Given this list of marker genes USP14, RAB6B, ATF6B, BBS5, ADCY6, B9D1, SPRY2, GDI1, TARDBP (TAR DNA binding protein), HECTD1, OTX1, ZFYVE9, CTAGE1, POU2F1, PDE12, U2SURP, ELAVL1 (ELAV like RNA binding protein 1), TIPARP, CYB561D1, N4BP3, SKAP2, TUBAL3, PTBP2, KMT2B, C3orf52, FASTKD1, CNPY4, ELMOD3, RELT, TTC28, PLEKHA5, RXRA, LHX1, TSPAN5, KLC4, KPNA6, ORC4, MYBPC1, RNF5, FBLN1, TFCP2L1, AUNIP, RIMKLB, TFDP2, KDM4A, PTGFRN, TMEM178B, PYM1, TIMM17A, ERG, LHFPL6, CDC25A, AGO1, CBX8, CDKL2, TMEM212, CDC42BPA, TAP2, SCD, EBAG9, CREBZF, RNF41, SLC37A4 (NCBI Gene Id 84965), IQCG, LRIG2, DBNDD2, SNX24, here is a description of the gene set: species: Homo sapiens Human Gene Set: MIR1224_3P from publication Chen Y, Wang X (PMID 31504780) Genes predicted to be targets of miRBase v22 microRNA hsa-miR-1224-3p in miRDB v6.0 with MirTarget v4 prediction scores > 80 (high confidence targets).